The following is a description of a gene set: species: Mus musculus Mouse Gene Set: MIR_7060_5P Genes predicted to be targets of miRBase v22 microRNA mmu_miR_7060_5p in miRDB v6.0 with MirTarget v4 prediction scores > 80 (high confidence targets). from publication Chen Y, Wang X (PMID 31504780), and this is the list of marker genes: St8sia4, Slc10a3, Slc22a8, Fbxo48, Gdf6, Fibin, Gja8, Rdx, Tenm3, Slc2a10, Prelid1 (PRELI domain containing 1), Nufip2, Avpi1, Fgf12, Mbp, Hnrnpll, Baz1a (NCBI Gene Id 217578), Gpr173, Sec62, Brs3, Prss23, Arid4a, Golga1, Tet3, Atrnl1, Zcchc2, Creb5, Ttll7, Gab2, Mphosph9, Trpm1